The following is a description of a gene set: Human Gene Set: GRASEMANN_RETINOBLASTOMA_WITH_6P_AMPLIFICATION from publication Grasemann C, Gratias S, Stephan H, Schüler A, Schramm A, Klein-Hitpass L, Rieder H, Schneider S, Kappes F, Eggert A, Lohmann DR (PMID 16007192) Genes changed in retinoblastoma tumors with respect to chromosome 6p amplifications. studied in species Homo sapiens The paediatric eye tumour retinoblastoma is initiated by inactivation of RB1, a tumour suppressor on chromosome 13q. In addition to RB1 loss, many retinoblastomas show other genetic alterations including gains on chromosomes 6p21-pter and 1q31-q32. Recently, the minimal region of gains on chromosome 6 was narrowed to band p22. We examined genomic gains and expression changes in primary retinoblastomas to identify potential target genes in 6p22. Quantitative multiplex PCR detected copy numbers > or = 3 in 25 (33%) tumours and no gains in 31 of 76 (40%) tumours. The remaining 20 (26%) samples showed gains only at some loci, most often including E2F3 and DEK in 6p22.3. Analysis of RNA from 21 primary retinoblastomas showed that expression levels of these and some other genes in 6p22 correspond to DNA gains. However, KIF 13A, a reported candidate oncogene on 6p, was expressed at low levels or absent. Clinical manifestation of tumours with gains at all 6p22 loci was distinct in that distribution of age at diagnosis was markedly shifted to older age compared to tumours with no or partial gains. In summary, our results suggest that DEK and E2F3 are potential targets of 6p gains in retinoblastoma., and this is the list of marker genes: DEK, NUP153, ABCF1, RPS10, LSM2, CSNK2B, TMX1, ELOVL5, E2F3, RAN, CACNA1A, POLR1C, TDP2, PRR3